Given this list of marker genes Vhl, Tsku, Foxe3, Jag1, Notch2, here is a description of the gene set: The process in which the ciliary body generated and organized. The ciliary body is the circumferential tissue inside the eye composed of the ciliary muscle and ciliary processes. studied in species Mus musculus Mouse Gene Set: GOBP_CILIARY_BODY_MORPHOGENESIS